The following is a description of a gene set: Reactome Pathway: Defective UGT1A1 causes hyperbilirubinemia studied in species Homo sapiens UDP-glucuronosyltransferases (UGTs) play a major role in the conjugation and therefore elimination of potentially toxic xenobiotics and endogenous compounds. The 1-1 isoform UGT1A1 is able to act upon lipophilic bilirubin, the end product of heme breakdown. Defects in UGT1A1 can cause hyperbilirubinemia syndromes ranging from mild forms such as Gilbert syndrome (GILBS; MIM:143500) and transient familial neonatal hyperbilirubinemia (HBLRTFN; MIM:237900) to the more severe Crigler-Najjar syndromes 1 and 2 (CN1, CN2; MIM:218800 and MIM:606785) (Sticova & Jirsa 2013, Strassburg 2010, Udomuksorn et al. 2007, Costa 2006, Maruo et al. 2000). part of: Metabolic disorders of biological oxidation enzymes, and this is the list of marker genes: UGT1A1